Given this list of marker genes Mri1, Adi1, Apip, Enoph1, Bhmt1b, Bhmt, Mtap, Bhmt2, here is a description of the gene set: Any process which produces an amino acid from derivatives of it, without de novo synthesis. Mouse Gene Set: GOBP_AMINO_ACID_SALVAGE species: Mus musculus